Given this list of marker genes RAP1A, CEBPG, PAPPA2, ZBTB44, POU2F3, FAM90A1, TSC1, THUMPD3, SPRED1, THYN1 (NCBI Gene Id 29087), CUX1, PPP2R2D, RASA4, EIF4G2, SLC19A4P, RASGEF1A, NRIP1, TOR1AIP1, NRG1, PTPN1, ZNF554, CCDC115, TAB2, CBX5, USP1, AFP, NFIA, SERBP1, AP4S1, FHIT, TMEM179, ARID1A, SOCS6, LAMTOR3, POU2F1, IGDCC3, ARB2A, ATP8A2, ANKS4B, CDIN1, ZNF451, UBR3, UBN1, CLIP1, UBE2K, TTBK2, THAP1 (THAP domain containing 1), PRICKLE1, JAKMIP3, TNFAIP8L3, NEUROG2, DARS2, MASTL, STXBP5, MOAP1, PRMT6 (NCBI Gene Id 55170), ZFHX4 (zinc finger homeobox 4), BMP7, ITGA1, TBC1D5, SDHA, IRX2, PDE10A, UBE2D2, KCNQ2, HS3ST3B1, AAK1, KRT72, CRHR2, UBXN4, RABGEF1, TJP1, TPT1, CBY2, SS18, here is a description of the gene set: studied in species Homo sapiens Genes predicted to be targets of miRBase v22 microRNA hsa-miR-1228-3p in miRDB v6.0 with MirTarget v4 prediction scores > 80 (high confidence targets). from publication Chen Y, Wang X (PMID 31504780) Human Gene Set: MIR1228_3P